The following is a description of a gene set: Mouse Gene Set: TABULA_MURIS_SENISTRACHEA_SMOOTH_MUSCLE_CELL_OF_TRACHEA_AGEING studied in species Mus musculus from publication Tabula Muris Consortium (PMID 32669714), and this is the list of marker genes: Tmed9, Cfl1, Bsg, Ly6e, S100a1, Chmp2a, Msn, Zbtb16, Ptms, Tgm2, Vamp8, Bgn, Prr13, Fxyd1, Dcxr, Krt19, Spint2, Jund, Arl6ip5, Pebp1, Tle5, Mgp